The following is a description of a gene set: Human Gene Set: GSE28726_NAIVE_CD4_TCELL_VS_NAIVE_VA24NEG_NKTCELL_DN Genes down-regulated in naïve T cells: CD4 versus Va24- NKT. studied in species Homo sapiens Microarray analysis was performed to determine the transcriptional profiles of NKT, CD1d-aGC+ Va24-, and CD4 T cells. from publication Constantinides MG, Picard D, Savage AK, Bendelac A (PMID 21632718), and this is the list of marker genes: IRF3, PRRG2, ADAM11, PPARD, LTB4R, STARD3, H1-4, VNN2, BIN1, HDAC6, ARID4B (AT-rich interaction domain 4B), GUCA2A, ENTREP2 (endosomal transmembrane epsin interactor 2), PRKACG, C2orf72, PYGM, SMAGP, SEC31B, PIM1, FAM3A (FAM3 metabolism regulating signaling molecule A), H1-10, ASIC3 (NCBI Gene Id 9311), HSD3B2, ITGA5, PIK3IP1, ZNF8 (zinc finger protein 8), TNFAIP3, CLDN9, PRKG2, CCDC69, AQP5, DLGAP4, DGCR2, NINL, MAD1L1, CA11, H4C2, BBIP1, FLOT2, CCR7, GLS2, RGS9, SORL1, H2BC14, PIAS3, GRIK3, UPK3A, CDC25B, ESR1, MYH11, TYR, AURKC, ASIC2, DLGAP1 (DLG associated protein 1), ADA, CD37, LINC00302, NXPH4, THRA, PLXNA2, MARCHF3, CENPE, HBEGF, DDIT4, PPP2R5D, ARHGAP4, PRDM1, ARHGEF11, FCER2, DLG5, MUC1, PCOLCE, SLC2A3, KAT7, KLF5, TBX19, NUMA1, CYFIP2, GCA, SLCO2B1, ATG13, ZKSCAN5, FGFR1, WWOX, CTSK, MCC, MYL2, DDIT3, MT1H, TUBB2A, SIK1, DGKA, ARTN, H2BC10, SUN2, MYO9B, FXYD3, HMGN2, TACR3, ACRV1, TPM2, MRNIP, DMPK, MPZL1, ZFP36L2, MAP4K2, RASGRP2, DNAJB1, SRPK3, MAPK11, TBX1, PLA2G4C, ARHGAP45, KCNA5, MXRA8 (matrix remodeling associated 8), JOSD1, RBM38, CDH2, CXCR4, CDC42BPA, SORBS3, CCR8, FAM168A, PNOC, MT2A, DUSP8, MDK, ADD3, CXCR6, CD300C, SETD1B, IL11RA, IKBKG (NCBI Gene Id 8517), ERICH1, ITIH4 (NCBI Gene Id 3701), CD302, PHYH, TLR1, ITGA2B, SUOX, MAZ, UTRN, CYP2D6, ADRA1A, ICAM3, OPRK1, CASQ2, OCRL, ABR, ITGB2, HEXIM1, TRAF3IP2, DISC1, RPS28, HMGB2, EYA2, ARSL, LIMK2, SNAP91, TRAM2, XDH, AFDN, SHOX, MICA, SCN7A, ZNF467, BTBD2, CYP3A5, JUND, CORO1A, P2RX1, PCDH7, PLCD1, SIT1, ALDH2, IFITM1, RDH5, ACVR2B, TFDP2, AREG, TXNIP, USP19, FCGRT, H2AC17, TMSB10, TRIB2, ACP5, PPEF2, TLE5, CIZ1, BCL11A, ANXA10, SIPA1, MCL1, ACAP1, PROZ, OPTN, CYP4F12